Given this list of marker genes EDN3, EIF6, POLB (NCBI Gene Id 5423), FBXO16, LIFR, ATG4D, MGAT4A, FAM83H, CCIN, TNFSF13B, CMPK2, CRYBB2, TREML2, CTSW, SPRR3, BCL3, PTAFR, FAM171A1, SLFN12, GPR155, MAS1, CYBB, EHD2, NPY4R, ANO1, GPR22, MAML2, SLC25A22, TMEM17, TNFAIP3, IL1F10, CCRL2, PSMB9, RNF14, MYO3A, CLEC4E, FAM241A, AMHR2, WIF1, ARL4C, CNIH3, HRCT1, C12orf75, HOXD4, FSD2, PARP9, KCNJ10, GUCY1B1, SMAD1, TCAP, CCL5, DNASE1L3, LCP2, IFIT2, CORO2B, DNAJB6, AKAIN1, SOCS1, GRIK1, FAM174A (family with sequence similarity 174 member A), SMIM3, KDM4D, TBC1D13, MAPRE2, SAP30, SFN, PDE6H, SH2D5, CD70, MYH11, STAT2, KLRD1 (NCBI Gene Id 92677), FAM162B, JHY, NUSAP1, SLC49A4, TMCO3, CYP24A1, DHX58, LGI1, RTP4, USP18, BBOX1, ZC3H6, COL11A2, MXD1, GREB1L, SGSH, B4GALNT4, VPREB1, C1QL3, FAM171B, EPB41L5, CETN1, IRF7, TMEM201, TMOD2, TMOD3 (tropomodulin 3), ENPP4, CH25H, CELA3B, GIPR, KIAA1614, ZNF446, C16orf78, NFKBIA, KHDC1L, FXR1, WDR86 (WD repeat domain 86), VLDLR, GPR20, PAX3, CD8B, ATP6V0B, TBX3, KIF4A, NOXRED1, VAPA, IL13RA2, MAPKAPK2, IRF1, ZIM3, SNTB1, MLKL (NCBI Gene Id 197259), WBP4, CDKN2A, FIGLA, UGGT2, CMTR1, FRY, EHD1 (NCBI Gene Id 10938), STXBP3, RNF114, ANKRD2, SIGLEC1, KCNAB1, IGFALS, COL4A2, USB1, F10, PDGFD, FSD1, BATF2, ODAD2, HTR1B, RNF214, THNSL2, CXCL13, IRF9, VWC2L, AMELX, MINAR1, IFIT3, MTMR6, MAPK14, STAT1, ADAMTS16, SCN5A, MX1, TRIM25, MYD88, TOR3A, SMS, CLVS1, TNS2, M6PR, COL12A1, EXTL1, CES5A, SLC30A6, GNMT, SVBP, SETDB2, SPATA18, CSRNP1, IL21R, ETV4, TLR1, ACTL9, ST8SIA2, PPP2R5A, CNTN6, TTC36, RGCC, C9orf43, ANXA7, CDH8, TENT5A, EFNA5, CNEP1R1, MX2, OASL, NOD1, EIF2D, HYAL3, ACP3, CGAS, GALNTL5, CPSF2, RIGI, here is a description of the gene set: from publication Manel N, Hogstad B, Wang Y, Levy DE, Unutmaz D, Littman DR (PMID 20829794) Dendritic cells (DC) serve a key function in host defense, linking innate detection of microbes to the activation of pathogen-specific adaptive immune responses. Whether there is cell-intrinsic recognition of HIV-1 by host innate pattern-recognition receptors and subsequent coupling to antiviral T cell responses is not yet known. DC are largely resistant to infection with HIV-1, but facilitate infection of co-cultured T-helper cells through a process of trans-enhancement. We show here that, when DC resistance to infection is circumvented, HIV-1 induces DC maturation, an antiviral type I interferon response and activation of T cells. This innate response is dependent on the interaction of newly-synthesized HIV-1 capsid (CA) with cellular cyclophilin A (CypA) and the subsequent activation of the transcription factor IRF3. Because the peptidyl-prolyl isomerase CypA also interacts with CA to promote HIV-1 infectivity, our results suggest that CA conformation has evolved under opposing selective pressures for infectivity versus furtiveness. Thus, a cell intrinsic sensor for HIV-1 exists in DC and mediates an antiviral immune response, but it is not typically engaged due to absence of DC infection. The virulence of HIV-1 may be related to evasion of this response, whose manipulation may be necessary to generate an effective HIV-1 vaccine. Genes up-regulated in monocyte-derived dendritic cells infected by: SIV versus HIV and SIV. Human Gene Set: GSE22589_SIV_VS_HIV_AND_SIV_INFECTED_DC_UP species: Homo sapiens